Given this list of marker genes Ncoa3, Rab5c, Synpo2, E2f2 (NCBI Gene Id 329958), Itga4, Zbtb41, Cd69, Kcnd2, Atf2, Rtn1, Egln3, Suv39h1, Arid4b, Fgf9, Znrf3, Zbtb5, Arhgap29, Hipk3, Myrf, Prdm8, Rab12, Tapt1, Mylk, Irf2bp2, Myocd, Skida1, Cul1, Btg1, Cpeb1, Caprin2, Miga2, Fxr1, R3hdm1, Ikzf2, Fam120a, Tfap4, Rnf216, Kdm1b, Ago1, Cdt1, here is a description of the gene set: Mouse Gene Set: MIR_467C_5P_MIR_467D_5P from publication Chen Y, Wang X (PMID 31504780) Genes predicted to be targets of miRBase v22 microRNA mmu_miR_467c_5p, mmu_miR_467d_5p in miRDB v6.0 with MirTarget v4 prediction scores > 80 (high confidence targets). studied in species Mus musculus